The following is a description of a gene set: Negative regulators of DDX58/IFIH1 signaling studied in species Homo sapiens Human Gene Set: REACTOME_NEGATIVE_REGULATORS_OF_DDX58_IFIH1_SIGNALING, and this is the list of marker genes: ITCH, ATG12, UBE2K, ATG5, OTUD5, RPS27A, UBC, UBB, UBE2L6, UBA7, IRF3, NLRC5, RNF135, TNFAIP3, UBE2D2, PIN1, IKBKE, RIGI, TBK1, RNF125, UBE2D3, ISG15, CYLD, RNF216, MAVS, IFIH1, TRAF3, TAX1BP1, UBA52, UBE2D1, HERC5, TRIM4, PCBP2 (poly(rC) binding protein 2), TRIM25, NLRX1